Given this list of marker genes OVOL2, BAP1, FAS, GNA11, ASB10, COL2A1, ADAMTS17, GRHL2, FOXE3, FN1, VSX1, GLIS3, LMX1B, ASPH, CHST14, DSE, LOXL1, COL18A1, CYSLTR2, CHRDL1, EFEMP1, TEK, COL8A2, NFIA, HGD, SLC39A14, PXDN, PTPN22, GNAQ, HMX1, ZEB1, PRSS56, CYP1B1, LTBP2, C1QTNF5, SF3B1, HLA-A, MYOC, PITX3, here is a description of the gene set: Abnormal intraocular pressure Human Gene Set: HP_ABNORMAL_INTRAOCULAR_PRESSURE studied in species Homo sapiens An anomaly in the amount of force per unit area exerted by the intraocular fluid within the eye.